The following is a description of a gene set: Mouse Gene Set: GOMF_INOSITOL_1_4_5_TRISPHOSPHATE_5_PHOSPHATASE_ACTIVITY Catalysis of the reaction: 1D-myo-inositol 1,4,5-trisphosphate + H2O = 1D-myo-inositol 1,4-bisphosphate + phosphate. species: Mus musculus, and this is the list of marker genes: Inpp5b, Inpp5j, Inpp5k, Ocrl, Synj1 (synaptojanin 1), Synj2